The following is a description of a gene set: studied in species Mus musculus Any process that modulates the frequency, rate or extent of the directed movement of amino acids into, out of or within a cell, or between cells, by means of some agent such as a transporter or pore. Mouse Gene Set: GOBP_REGULATION_OF_AMINO_ACID_TRANSPORT, and this is the list of marker genes: Htr2c, Cck, Sv2a, Snca, Slc7a5, Lep, Arl6ip5, Slc38a1, Rgs4 (NCBI Gene Id 19736), Slc38a3 (solute carrier family 38, member 3), Syt4, Arg2, Slc12a2, Rab3gap1, Ntsr1 (NCBI Gene Id 18216), Tnf, Slc6a1, Il1b, Slc17a8, Slc38a2, Slc43a1, Dtnbp1, Nr3c1 (nuclear receptor subfamily 3, group C, member 1), Avp, Gabbr1, Trh, Dpysl2, Cltrn, Grik1, Il1rn, Avpr1a, P2rx7, Arhgef11, Htr1a, Arg1, Grin2b, Arl6ip1, Abat, Itgb1, Adora2a, Slc43a2, Ace2, Psen1, Npy5r, Kmo, Htr6, Septin2, Grm2, Agt, Slc36a2, Htr1b, Prkg1, Rgs2, Hrh3, Grm7, Stxbp1, Per2, Slc15a1, Adora1